Given this list of marker genes NAA10, BUB1, SLF1, MAU2, MACROH2A1, DSCC1, TNKS (tankyrase), NSMCE2, ATRX, NIPBL, SLF2, RB1 (NCBI Gene Id 92728), SMC5, here is a description of the gene set: The process in which the association between sister chromatids of a replicated chromosome is maintained as chromosomes condense, attach to the spindle in a bipolar orientation, and congress to the metaphase plate. species: Homo sapiens Human Gene Set: GOBP_MAINTENANCE_OF_SISTER_CHROMATID_COHESION